Given this list of marker genes Lrp6, Tgfbr2, Bmpr1a, Sav1, Nkx2-5, Fzd1, Zfpm1, Prox1, Nsd2, Heyl, Tgfbr1, Nfatc1, Cited2, Fgfr2, Id2, Sox4, Hes1, Vangl2, Mir20a, Nos3, Hey2, Smad4, Mir18, Tbx3, Slit2, Hey1, Sox11, Rbm15, Mir17, Egln1, Bmp4, Aplnr, Tgfb2, Fgfrl1, Gja5 (gap junction protein, alpha 5), Rbpj, Zfpm2, Notch1, Robo1, Mir92-1, Slit3, Robo2, Mir19b-1, Tgfbr3, Mir19a, Acvr1, Pitx2, Adamts19, Fzd2, Smad7, Bmpr2, Wnt11, Nog, here is a description of the gene set: Mouse Gene Set: GOBP_VENTRICULAR_SEPTUM_MORPHOGENESIS studied in species Mus musculus The developmental process in which a ventricular septum is generated and organized. A ventricular septum is an anatomical structure that separates the lower chambers (ventricles) of the heart from one another.